Given this list of marker genes FGF9, MIR125B1, APLNR, HEY2, MIR145, MYOCD, SRF, QKI, SOD2, KIT, GATA6, PITX2, SGCB, MIR140, DNMT1, MIR221, NOTCH1, MIR21, COMP, GPER1, CTH, NFATC4, MESP1, NFATC2, MIR18A, PDCD4, VEGFA, ENG, MIR100, RAMP2, MIR424, ADM, HES1, NFATC3 (NCBI Gene Id 82543, nuclear factor of activated T cells 3), EDNRA, NFATC1, MIR26A1, PDGFB, MIR1-1, EFEMP2 (NCBI Gene Id 30008), MIR15B, here is a description of the gene set: The process in which a relatively unspecialized cell acquires specialized features of a vascular smooth muscle cell. Human Gene Set: GOBP_VASCULAR_ASSOCIATED_SMOOTH_MUSCLE_CELL_DIFFERENTIATION species: Homo sapiens